Given this list of marker genes CYC1, CETN2, NSUN7, ATF7IP, PDCD6IP, CAPN5, MRPL42, CASQ2, GHITM, CDK14, CAMSAP2, NBPF14, FNIP1, CTDSPL2, COX11, CACUL1, HSPB1, USF3, KPNB1, NEDD9, CIP2A, HIF1A, BAZ1A, BRPF1, GDAP2, SCAI, ASPN, PCDHB14, RAB6B, LIX1L, ZNF516, CALHM5, CCDC102B, SLK (STE20 like kinase), GIT2, SLC41A1, PTK2, CFHR3, SAMD9L, TRUB2, EIF4E, MME, HTN1, ZSCAN31, NSD2, SYT15, SAP30L, NECAB1, SIAH1, HDAC9, IMPG2 (NCBI Gene Id 51443), ELK4, PAG1, DNAJC10, ZFHX3, GOPC, MS4A2, UBE2F (ubiquitin conjugating enzyme E2 F (putative)), TRPM7, ELP4, PHF14, GUCD1, ZNF670, TOGARAM1, KRTAP11-1, IL20RA, POLR2M, CREB1, ZNF239, PRSS12, EXO5, HAPSTR1, MINDY2, SYNPR, EVI5, COL11A1, TAF8, DCAF5, CISD1, RNF11, NBPF20, FLI1, TIAM1, TRHDE, TPD52L3, FNDC1, FBXW2, NR1I2, MYBL1, YES1, RTKN2, ANO3, GAREM1, THUMPD1, CLOCK, FNBP4, SESTD1 (NCBI Gene Id 91404), DNAJC25, FMN2, FCHO2, LRRC3, KCNS3, ABI1, CROT, CPD, TMEM185B, IL22RA2, GRM5, XRRA1, PDE4DIP, WDR33, CEP85L, TTC32, COMMD2, SUMO2, IGSF3, GCOM1, HDGFL3, NCK2, SBSPON, PEAK1, IQCE, KCNMB3, CYP7B1, NBPF9, ZNF250, MPPE1 (NCBI Gene Id 65258), DSG3, ITFG1, SLC6A2, NPAS3, STAU1, PGGT1B, PTPRB, SP100, DCT, TERB2, TSLP, STX7, PYROXD1, FRY, PRKG2, KIAA1191, PI15 (peptidase inhibitor 15), BTG1, MFSD4A, PYGO1, GABPA, ZNF620, LRATD1 (NCBI Gene Id 654112), KBTBD6, PAQR8, GPR155, TRDN, ZNF100, ROBO1, ANKRD6, TP53INP1, BTC, NUSAP1, ZNF704, EXTL2, NIPAL1, STRBP, DCP2, GABRA1 (NCBI Gene Id 2554), ZDHHC21, ZNF148, SPART, GABRA4, GGCX, MEGF11, SLC12A1, KREMEN1, PTK7, ARL11, ZBTB20, ZNF208, ZNF782, ENO4, PDE1A, PDCD4 (NCBI Gene Id 27250), TXN, NR4A2 (nuclear receptor subfamily 4 group A member 2), ICMT, FAM90A1, ADARB1, CDC37L1, GADD45A, NARS1, PCLO, CPPED1, ASAP1, PSD3, FSD1L, MOB1A, SH3PXD2A, TRAM2 (NCBI Gene Id 9697), FAR2, KPNA1, ANKS4B, ABCA1, AAK1, CILK1, PALM2AKAP2, INPP4A, FBXO5, DLG4, SATB1, GPR158, NBPF15, CEP41, RBL1, CPNE3, STAG1, ICE2, here is a description of the gene set: species: Homo sapiens from publication Chen Y, Wang X (PMID 31504780) Human Gene Set: MIR580_3P Genes predicted to be targets of miRBase v22 microRNA hsa-miR-580-3p in miRDB v6.0 with MirTarget v4 prediction scores > 80 (high confidence targets).